Given this list of marker genes Trem2, Gimap3, Pgc, C3, Gimap5, Il1b, Hpx, Nod2, Zp3, Ccr7, Il17a, Ptprc, Phb1, H2-DMa, Lta, Klk7, Mbl2, Tnf, Fcer2a, Il17f, Acod1, Klk5, here is a description of the gene set: species: Mus musculus Mouse Gene Set: GOBP_POSITIVE_REGULATION_OF_HUMORAL_IMMUNE_RESPONSE Any process that activates or increases the frequency, rate, or extent of a humoral immune response.